The following is a description of a gene set: species: Homo sapiens The term peptic ulcer refers to acid peptic injury of the digestive tract, resulting in mucosal break reaching the submucosa. Peptic ulcers are usually located in the stomach or proximal duodenum, but they can also be found in the esophagus or Meckel's diverticulum. Infection with Helicobacter pylori and the use of non steroidal antiinflammatory drugs (NSAIDs) or aspirin are the main risk factors of both gastric and duodenal peptic ulcers. Human Gene Set: HP_PEPTIC_ULCER Peptic ulcer, and this is the list of marker genes: ARID1B, BUD23, TMEM270, CDC73, SLCO2A1, GTF2IRD2, STX1A, BAZ1B, LIMK1, METTL27, TET2, PLA2G4A, GNA11, VPS37D, AP2S1, HPGD, CDKN2C, ASXL1, NCF1, ELN, SRSF2, TBL2, DNAJC30, CISD2, GTF2IRD1, STAT3, CLIP2, GBA1 (glucosylceramidase beta 1), CDKN1A, FKBP6, CDKN2B, CDKN1B, KIT, WFS1 (NCBI Gene Id 94141), MEN1, GTF2I, RFC2, EIF4H